The following is a description of a gene set: studied in species Mus musculus electronically inferred by orthology from the curated human pathway Reactome Pathway: Regulation of localization of FOXO transcription factors part of: FOXO-mediated transcription This event has been computationally inferred from an event that has been demonstrated in another species.<p>The inference is based on the homology mapping from PANTHER. Briefly, reactions for which all involved PhysicalEntities (in input, output and catalyst) have a mapped orthologue/paralogue (for complexes at least 75% of components must have a mapping) are inferred to the other species., and this is the list of marker genes: Sfn, Foxo6, Foxo4